The following is a description of a gene set: species: Homo sapiens Human Gene Set: GOBP_MESENCHYMAL_EPITHELIAL_CELL_SIGNALING Any process that mediates the transfer of information from a mesenchymal cell to an epithelial cell where it is received and interpreted., and this is the list of marker genes: TNC, FOXA1, FGF10, FGF7, WNT5A, HOXA5, HGF, FGFR1, WNT2B